Given this list of marker genes CEP85L, RELN, DNAJC5, DEPDC5, MMACHC, NPRL2, TTR, CSF1R, SON, CACNA1A, PDGFRB, FIG4, LGI1, CDH2, NPRL3, CLN6, here is a description of the gene set: Human Gene Set: HP_AUDITORY_HALLUCINATION species: Homo sapiens Perception of sounds without auditory stimulus. Auditory hallucination